The following is a description of a gene set: Mouse Gene Set: GOBP_PHOSPHATIDYLCHOLINE_METABOLIC_PROCESS studied in species Mus musculus The chemical reactions and pathways involving phosphatidylcholines, any of a class of glycerophospholipids in which the phosphatidyl group is esterified to the hydroxyl group of choline. They are important constituents of cell membranes., and this is the list of marker genes: Pla2g2e, Pla2g1b, Dbi, Gdpd3 (NCBI Gene Id 68616), Abca3, Pla2g10, Plaat1, Pnpla7, Apoa4, Fabp5, Pnpla8, Pla2g2f, Pla2g4a, Apoa1, Pemt, Gpld1, Pnpla6, Nr1h3, Rab38, Slc27a1, Pla2g7, Pcyt1b, Pla2g2d, Pla2g3, Chka, Acsl3, Abhd3, Pla2g15, Gpat4, Pnliprp2, Pla2g2a, Pla2g2c, Fgf7, Lcat, Pla2g6, Mboat7, Lipc, Lpcat3, Scarb1, Apoc1, Pon1, Pla2g5, Mecp2 (methyl CpG binding protein 2), Lpcat1, Fabp3, Mboat1, Dhrs7b, Chpt1, Ldlr, Pla2g4c, Lpgat1, Pcyt1a, Oc90, Mboat2, Capn2, Enpp2, Chkb, Apoa2, Plb1 (NCBI Gene Id 78261), Lrat, Lpcat4, Nr1h2, Cept1, Mfsd2a, Lpcat2